Given this list of marker genes Kpna3, Kpna2rt, Ipo11, Ipo4, Kpna7, Tmco6, Tnpo2, Tnpo1, Nutf2, Kpna1, Kpna4, Snupn, Ipo9, Ipo5 (NCBI Gene Id 97586), Kpna2, Nutf2-ps1, Kpnb1, Ranbp6, Hikeshi, Kpna6, here is a description of the gene set: Mouse Gene Set: GOMF_NUCLEAR_IMPORT_SIGNAL_RECEPTOR_ACTIVITY Combining with a nuclear import signal (NIS) on a cargo to be transported, to mediate transport of the cargo through the nuclear pore, from the cytoplasm to the nuclear lumen. The cargo can be either a RNA or a protein. studied in species Mus musculus